The following is a description of a gene set: species: Mus musculus A cytoskeletal structure that forms a distinct elongated structure, characteristically 10 nm in diameter, that occurs in the cytoplasm of eukaryotic cells. Intermediate filaments form a fibrous system, composed of chemically heterogeneous subunits and involved in mechanically integrating the various components of the cytoplasmic space. Intermediate filaments may be divided into five chemically distinct classes: Type I, acidic keratins; Type II, basic keratins; Type III, including desmin, vimentin and others; Type IV, neurofilaments and related filaments; and Type V, lamins. Mouse Gene Set: GOCC_INTERMEDIATE_FILAMENT, and this is the list of marker genes: Nefm, Krt9, Krt40, Eppk1, Upp2 (uridine phosphorylase 2), Krt15, Tchp, Csnk1a1, Ldlrap1, Krtap19-1, Krt25, Krtap19-5, Bbln, Nrp1, Krt24, Nefh, Krtap3-3, Vmac, Krtap3-1 (NCBI Gene Id 69473), Krt17, Des, Krtap14, Gsn, Krt76, Krt12, Krt33b, Htr2a, Krt78, Krtap26-1, Krtap4-6, Krt39, Krt20, Slc1a4, Casp14, Krt79 (keratin 79), Krt6b, Krtap19-2, Krtap9-3, Krtap5-2, Nme2, Krt71, Krtap6-5, Krt34, Jup, Shank2, Krt26, Krtap29-1, Krt14, Krtap5-4, Krt87, Krt82, Krtap19-9b, Gm5478, Krt23, Krtap5-1, Prph, Krt10, Krtap12-1 (keratin associated protein 12-1), Krt28, Hspa8, Krt7, Krt35, Krt81 (NCBI Gene Id 64818), Lmntd2, Ina, Eif6, Myo5a, Krt4, Krtap16-3, Tlk2, Nefl, Krtap16-1, Krt90, Iffo2, Fam83h, Dst, Lmntd1, Gja1, Krt222, Mns1, Plec, Dsp, Gper1, Krtap15-1, Krtap6-2, Krt42, Pcp4, Bfsp1, Krt32, Lmnb1, Dmd, Lmna, Nes, Bfsp2, Krt27, Krt2, Nme1, Krtap19-3, Krt75, Krtap7-1, Krt1, Krtap21-1, Krt83, Krtap19-4, Adora2a (NCBI Gene Id 11540), Krt36, Sync (syncoilin), Krt73, Ppl, Krt6a, Krt13, Krt77, Krt74, Lmnb2, Krt5, Fbf1, Narf, Gfap, Krt33a, Iffo1, Rtn2, Krt84, Cldn11, Krt85, Gm5414, Vim, Krtap5-3, Krt8, Krt86, Krt31, Synm, Macf1 (microtubule-actin crosslinking factor 1), Krt80, Krt18, Krtap8-1, Pkp2, Krtap5-5, Krt72, Krt16, Dyrk1a, Evpl, Krtap3-2, Krt19